The following is a description of a gene set: species: Mus musculus Mouse Gene Set: chr15B2, and this is the list of marker genes: Ropn1l, Cct5, Gm23033, 9630009A06Rik, Gm18003, 4930570B17Rik, Gm26416, 4930430F21Rik, Gm26163, Ankrd33b, Gm24554, Gm49208, Atpsckmt, Gm6361 (predicted gene 6361), Gm46522, Gm23327 (NCBI Gene Id 115485998), Dap, Gm5212, Ctnnd2, Cmbl, Fam136b-ps, Marchf6